Given this list of marker genes DUSP16, RGSL1, MS4A14, RICTOR, FAM210B, SHISA9, ADCY7, DLST, ZNF827, ERG28, PLET1 (placenta expressed transcript 1), STAT1, CCDC40, MTCL2, LIMA1, SAMD4A, SRSF10, ZFP91, KDM3B, CYP21A2, SUCLG2 (NCBI Gene Id 8801), RALGAPA2, MINDY4, ADM, RBFOX3, GPC6 (glypican 6), PAX1, SLC8A3, NAA50, BEAN1, TNRC6C, SVIP, ETV5, CREBRF, TTC17, NR1H3, LRP11, CCNJ, FRS2, BRWD1, SMAD3, SLC11A1 (solute carrier family 11 member 1), UGCG, UBA52, DMXL1, PROSER2, GNB1, SSH2, FBXO36, TDG, RNF212, CPSF2, ZNF514, LRATD2, NECTIN1, BPTF, C14orf28, VGLL3, ZNF81, ATP2C1, JPH4, CBL, TLCD5, CHRM2 (cholinergic receptor muscarinic 2), AZIN1, TRMT13, ITGA5, BEST3, CHPF2, ADPRH, RHOBTB1, CREB5, PTCHD1 (NCBI Gene Id 139411), MLLT6, TBC1D7, SAMSN1, SEMA3D, CXXC4, DACT1, MMAB, KIF7, ZBTB34, SLC8A1, RBMS3, MKNK1, CCDC68, ARHGEF37, PHEX, PIK3C2B, IGLON5, ADAMTS6, PDP1, SLC22A10, ANO6, here is a description of the gene set: Genes predicted to be targets of miRBase v22 microRNA hsa-miR-6886-3p in miRDB v6.0 with MirTarget v4 prediction scores > 80 (high confidence targets). studied in species Homo sapiens Human Gene Set: MIR6886_3P from publication Chen Y, Wang X (PMID 31504780)